The following is a description of a gene set: studied in species Homo sapiens Studies of gene regulation by oxygen have revealed novel signal pathways that regulate the hypoxia-inducible factor (HIF) transcriptional system through post-translational hydroxylation of specific prolyl and asparaginyl residues in HIF-alpha subunits. These oxygen-sensitive modifications are catalyzed by members of the 2-oxoglutarate (2-OG) dioxygenase family (PHD1, PHD2, PHD3, and FIH-1), raising an important question regarding the extent of involvement of these and other enzymes of the same family in directing the global changes in gene expression that are induced by hypoxia. To address this, we compared patterns of gene expression induced by hypoxia and by a nonspecific 2-OG-dependent dioxygenase inhibitor, dimethyloxalylglycine (DMOG), among a set of 22,000 transcripts, by microarray analysis of MCF7 cells. By using short interfering RNA-based suppression of HIF-alpha subunits, we also compared responses that were dependent on, or independent of, the HIF system. Results revealed striking concordance between patterns of gene expression induced by hypoxia and by DMOG, indicating the central involvement of 2-OG-dependent dioxygenases in oxygen-regulated gene expression. Many of these responses were suppressed by short interfering RNAs directed against HIF-1alpha and HIF-2alpha, with HIF-1alpha suppression manifesting substantially greater effects than HIF-2alpha suppression, supporting the importance of HIF pathways. Nevertheless, the definition of genes regulated by both hypoxia and DMOG, but not HIF, distinguished other pathways most likely involving the action of 2-OG-dependent dioxygenases on non-HIF substrates. Human Gene Set: ELVIDGE_HIF1A_AND_HIF2A_TARGETS_DN from publication Elvidge GP, Glenny L, Appelhoff RJ, Ratcliffe PJ, Ragoussis J, Gleadle JM (PMID 16565084) Genes down-regulated in MCF7 cells (breast cancer) after knockdown of both HIF1A and HIF2A by RNAi., and this is the list of marker genes: FYN, EGLN1, VEGFC, PPFIA4, IGFBP3, PGAP1, RRAGD, YEATS2, NDRG1, SRD5A3, ZNF395, FAM162A, EGFR, SPAG4, RNASE4, OBSL1, DSC2, ENO2, VEGFA, HK2, DPYSL2, GPRC5A, FOS, CSRP2, SH3GL3, ITPR1, STBD1, LOX, ZNF292, CXCR4, EIF5A, SPOCK1, ANKZF1, SOX9 (SRY-box transcription factor 9), CA9, EGR1, PGM1, PDK1, RBPJ, SH2B2, DST, GLRX, ATXN1, GBE1, FAM13A, MXI1, IGFBP5, HILPDA, CITED2, SAMD4A, AHNAK2, PLAC8, LIMCH1, SFXN3, TMEM45A, GJA1, CCNG2, KDM4B, VLDLR, ALDOC, CAVIN1, S100A4 (S100 calcium binding protein A4), PLAUR, BNIP3L, RASA4, PDGFB, ADM, DPYSL4 (dihydropyrimidinase like 4), HEY1, GYS1, ANG, AKAP12, PGK1, LOXL2, STC1, SRPX, ZNF654, P4HA1, PAM, INSIG2, CCN5, EGLN3, EFNA3, HLA-DRB1, BNIP3, UPK1A, PLIN2, SCNN1B, QSOX1, MAGED4B, ERO1A, NOL3, AK4, KRT15, P4HA2, WSB1, BHLHE40, CYB5A, LOXL1, SLC2A1, ANGPTL4, ILVBL, SERPINE1, PFKFB3, CAV1